The following is a description of a gene set: Any process that activates or increases the frequency, rate or extent of the neurotrophin TRK receptor signaling pathway. Human Gene Set: GOBP_POSITIVE_REGULATION_OF_NEUROTROPHIN_TRK_RECEPTOR_SIGNALING_PATHWAY studied in species Homo sapiens, and this is the list of marker genes: CYFIP1, CYFIP2, PPP2R5B, WASF1, TMEM108